Given this list of marker genes LYN, GPR55, QKI, HSPA9, BCL6, LRRC17, IFNL1, TMEM131L, APCS, MIR21, HOXA7, ZBTB46, IL4R, SFRP1, CLEC4G, TOB2, FSTL3, CD74, BMP4, SOCS1, IHH, CD69, MYC, TNFSF4, SNAI2, ERBB2, PRDX2, ZFPM1, FOXJ1, TBX21, NF1, UBASH3B, FBXO7, TAOK3, PGLYRP3, TNFRSF11B, TRIB1, PIK3R1, LGALS1, MIR221, TNFAIP6, FOXP3, ZC3H8, PRDM16, LAG3, RC3H2, IL4, TNFSF18, RARA, IRF1, INHA, MIR125B1, RAG2, ZNF675, INPP5D, SHH, RC3H1, LILRB3, ZBTB7B, CDKN2A, CR1, LILRB4, ZC3H12A, CCL3 (C-C motif chemokine ligand 3), INHBA, DTX1, CALCA, PGLYRP2, JAK3, TCTA, FGL2, CDK6, CLDN18, CEBPA, LTF, TMEM176A, ID2, CLEC12A (C-type lectin domain family 12 member A), IAPP, GLI3, IFNB1, FBXW7, CEACAM1, RUNX1, CARTPT, PIAS3, GPR137, CBFB, TMEM178A, TLR4, FBN1, SOCS5, CUL4A, HLA-G, IFNA2, TMEM176B, NRARP, ADIPOQ, ANXA1, STAT5A, HMGB1, LOXL3, GPR68, MIR30B, SLC4A2, CTLA4, GPR137B, MDK, HMGB3, RUNX3, MIR222, HLX, ASCL2, PTPN2, SMAD7 (NCBI Gene Id 4092), IL2, FCGR2B, ERFE, PGLYRP1, LILRB1, CTNNB1, C1QC, IL17D, TLR3, MIR486-1, TSC22D1, GATA2, MAFB, here is a description of the gene set: Any process that stops, prevents or reduces the frequency, rate or extent of hemopoiesis. Human Gene Set: GOBP_NEGATIVE_REGULATION_OF_HEMOPOIESIS studied in species Homo sapiens